Given this list of marker genes Pea15a (proliferation and apoptosis adaptor protein 15A), Dusp9 (NCBI Gene Id 75590), Cdk1, Dusp16, Mapk3, Il6ra, Map2k1, Dusp7 (dual specificity phosphatase 7), Dusp5, Dusp2, Il6, Tyk2, Map2k2, Dusp6, here is a description of the gene set: This event has been computationally inferred from an event that has been demonstrated in another species.<p>The inference is based on the homology mapping from PANTHER. Briefly, reactions for which all involved PhysicalEntities (in input, output and catalyst) have a mapped orthologue/paralogue (for complexes at least 75% of components must have a mapping) are inferred to the other species. Reactome Pathway: RAF-independent MAPK1/3 activation studied in species Mus musculus part of: MAPK1/MAPK3 signaling electronically inferred by orthology from the curated human pathway